Given this list of marker genes XRCC2, SLC1A2, DNAJB14, SCAF11, NR1D2, FUT6, DGCR11, IL5, CSRNP3, CCIN, XRCC3, GABRB3, CCL1, KIF3A, EPHA2, NR5A1, NTM, UMOD, ZNF148, HIPK2, ANKRD11, RNF115, MAGEA1, HOXB7, SV2C, MAP1B, ZBTB38, ZNF136, SERPINF2, SPIN1, SLC10A1, CYP2C18, FAM169A, here is a description of the gene set: studied in species Homo sapiens Cytoarchitectural abnormalities have been described in the prefrontal cortex of subjects with schizophrenia, bipolar disorder and depression. However, little is known about the gene expression profiles associated with these abnormalities. Genome-wide expression profiling technology provides an unbiased approach to identifying candidate genes and biological processes that may be associated with complex biological traits such as cytoarchitecture. In this study, we explored expression profiles associated with the abnormalities by using publicly available microarray metadata and cytoarchitectural data from post-mortem samples of the frontal cortex from 54 subjects (schizophrenia, n=14; bipolar disorder, n=13; depression, n=12 and controls n=15). Correlation analysis between genome-wide expression levels and cytoarchitectural traits revealed that genes were significantly correlated with a decrease in the number of perineuronal oligodendrocytes across all subjects. A total of genes were significantly correlated with a decrease in density of calbindin-positive interneurons across all subjects. Multiple biological processes including cellular metabolism, central nervous system development, cell motility and programmed cell death were significantly overrepresented in both correlated gene lists. These findings may provide novel insights into the molecular mechanisms that underlie the cytoarchitectural abnormalities of perineuronal oligodendrocytes and calbindin-containing GABAergic interneurons in the prefrontal cortex of the major psychiatric disorders. Human Gene Set: KIM_ALL_DISORDERS_OLIGODENDROCYTE_NUMBER_CORR_DN Genes whose expression was significantly and negatively correlated with the number of perineuronal oligodendrocytes in the layer III of BA9 brain region. from publication Kim S, Webster MJ (PMID 18762803)